Given this list of marker genes Hsd17b4, Hsd17b10, Hadha, Hadh, Ehhadh, here is a description of the gene set: Catalysis of the reaction: (S)-3-hydroxyacyl-CoA + NAD+ = 3-oxoacyl-CoA + NADH + H+. Mouse Gene Set: GOMF_3_HYDROXYACYL_COA_DEHYDROGENASE_ACTIVITY studied in species Mus musculus